The following is a description of a gene set: Human Gene Set: GOBP_OLIGODENDROCYTE_PROGENITOR_PROLIFERATION The multiplication or reproduction of oligodendrocyte progenitor cells by cell division, resulting in the expansion of their population. Oligodendrocyte progenitors give rise to oligodendrocytes, which form the insulating myelin sheath of axons in the central nervous system. studied in species Homo sapiens, and this is the list of marker genes: MIOS, LYN, EMX1, SIRT2, PTPRZ1, CDH2, LRP2